The following is a description of a gene set: Mouse Gene Set: GOBP_AMELOBLAST_DIFFERENTIATION studied in species Mus musculus The process in which a relatively unspecialized cell acquires specialized features of an ameloblast, a cylindrical epithelial cell in the innermost layer of the enamel organ., and this is the list of marker genes: Dspp, Bmp7, Tbx1, Ntf5, Bmp2, Tjp1, Ascl5, Fst, Pkp1, Bmp4, Enam, Wdr72